Given this list of marker genes DCLRE1B, OXGR1, SCN1A, KLHL23, CDH8, DOCK8, BOLA2-SMG1P6, RFX3, TERF2, PDS5A, CREBZF, RAP2A, THNSL1, SLC9A6, FPGT, DCN, OXR1, RNF144B (ring finger protein 144B), ETV6, MRPS10, SLC15A5, DST, KY, CREBBP, C6orf62, PURA, DARS1 (NCBI Gene Id 1615), ARHGEF12 (NCBI Gene Id 55406), SBSPON, SEH1L, INO80, ELOVL4, EIF3B, FAM181A, MIER1, IGF2BP3, FBXO28, ANGPTL3, TAF5L, ACTC1, ZNF550, AP4E1, ULK2, TCEA1, RCC2, HSPA4L, GPR137C, ELK4, CALHM5, TMEM30A, ZSCAN30, VASH1, USP10, KDM7A, DENND5B, USP1, TRIM37, ARSG, EGR1, STK39, NGLY1, ATP6V1B2, CALCOCO1, ADGRV1, ZCCHC2 (NCBI Gene Id 84810), ENO4, GDPD1, IPO5, NIN, ARMC5, MDM2, CDK8, PSMD10, COPS2, STRN3, EIF3J, LACC1, PHF21A, SLC39A2, DEFB132, ZNF831, HOXA2, TBC1D12, CGGBP1, USP44, M1AP, PNN, ANKFY1, STRN4, RFESD, SNAP91, ARMT1, SPIN3, SLC22A23, JARID2, PIP4K2A (NCBI Gene Id 5305), SLC5A6, KIAA1328, PLAGL2, NONO, here is a description of the gene set: from publication Chen Y, Wang X (PMID 31504780) studied in species Homo sapiens Genes predicted to be targets of miRBase v22 microRNA hsa-miR-3145-5p in miRDB v6.0 with MirTarget v4 prediction scores > 80 (high confidence targets). Human Gene Set: MIR3145_5P